Given this list of marker genes RB1, VPS35, IGF2R, HLA-B, LCLAT1, HLA-A, here is a description of the gene set: Human Gene Set: KUROKAWA_LIVER_CANCER_EARLY_RECURRENCE_DN from publication Kurokawa Y, Matoba R, Takemasa I, Nagano H, Dono K, Nakamori S, Umeshita K, Sakon M, Ueno N, Oba S, Ishii S, Kato K, Monden M (PMID 15288478) Genes down-regulated in hepatocellular carcinoma (HCC) with early recurrence. species: Homo sapiens BACKGROUND/AIMS: Hepatocellular carcinoma (HCC) has a very poor prognosis, due to the high incidence of tumor recurrence. As the current morphological indicators are often insufficient for therapeutic decisions, we sought to identify additional biologic indicators for early recurrence. METHODS: We analyzed gene expression using a PCR-based array of genes in 100 HCC patients. Informative genes predicting early intrahepatic recurrence were selected by random permutation testing, and a weighted voting prediction method was constructed. Following estimation of prediction accuracy, a multivariate Cox analysis was performed. RESULTS: By permutation testing, we selected genes demonstrated distinct expression patterns differing significantly between recurrence cases and recurrence-free cases. Our prediction method, using the 20 top-ranked genes, correctly predicted the early intrahepatic recurrence for 29 of 40 cases within the validation group, and the odds ratio was 6.8 (95%CI 1.7-27.5, P = 0.010). The 2-year recurrence rates in the patients with the good signature and those with the poor signature were 29.4 and 73.9%, respectively. Multivariate Cox analysis revealed that molecular-signature was an independent indicator for recurrence (hazard ratio 3.82, 95%CI 1.44-10.10, P = 0.007). CONCLUSIONS: Our molecular-based prediction method using genes is clinically useful to predict early recurrence of HCC.